Given this list of marker genes APRT, BCR, LAMA3, CIITA, KAT5, RNU7-1, UBAP2L, EP300, LAMB3, TRAIP, DZIP1L, RFC2, PALB2, PKD1, BRCA1, FANCE, CLEC7A, PRMT7, SLX4, MED12, MINPP1, ADNP, KAT6A, LTBP1, CLDN19, SMARCA2, DNAJB11, CLIP2, SATB1, BRCA2, TNXB, IL17RC, FANCI, PIK3CG, MAN2B1, EIF4H, GTF2I, SLC5A2, STX1A, LIMK1, LRIG2, EXT1, RELB, CDC42BPB, WFS1, CR2, CLDN16, TMEM270, HPSE2, NBN, UBE2T, G6PC3, EFEMP2, SLC35C1, GRHPR, PRKCD, ALMS1, CHRNA3, ZNF699, PKD2, AGXT, ARL3, LAMC2, ISL1, MLXIPL, FANCD2, PEPD, HLA-B, GTF2IRD2 (NCBI Gene Id 84163), FANCL, RAD21, BRIP1, TP63, TXNRD2, FOXC2, CISD2, ATP7A, BICC1, KCTD1, MSN, TBK1, MAD2L2, LMNB1, PKHD1, ATRX, PIK3CD, NAE1, MRAP, CRKL, VPS37D, HPS6, BLM, FANCC, RFWD3 (NCBI Gene Id 55159), TBL2, IL17RA, ELN, BAZ1B, BNC2, SOX17, FKBP6, METTL27, ALG5, SLC46A1, FANCG, BUD23, TRPS1, FOXN1, RAD51C, CFI, KNSTRN, SAMD9, NNT, THOC6, KANSL1, GANAB, IL2RB, IGKC, RAD51, IGHG2, GTF2IRD1, PNP, NCF1, XRCC2, POLR3GL, DNAJC30, CHRM3, FANCB, BTK (Bruton tyrosine kinase), FLVCR1, MYL9, FANCM, MC2R, COL6A1, MNX1 (NCBI Gene Id 7987, motor neuron and pancreas homeobox 1), CREBBP, STAR, SLC3A1, FANCA, HSPA9, TRAF3IP2, DYRK1A, EN1, MAPK1 (NCBI Gene Id 5594), WASF1, FARSB, FBLN5, ERCC4, POLR3A, IL17F (NCBI Gene Id 112744), FANCF, AMN (amnion associated transmembrane protein, NCBI Gene Id 81693), EHMT1, STIM1, SLC7A9, IFT140, FOCAD, HOXA13, NCF2, ALG9, here is a description of the gene set: Repeated infections of the urinary tract. Human Gene Set: HP_RECURRENT_URINARY_TRACT_INFECTIONS studied in species Homo sapiens Recurrent urinary tract infections